The following is a description of a gene set: Human Gene Set: HP_FACIAL_HEMANGIOMA Facial hemangioma Hemangioma, a benign tumor of the vascular endothelial cells, occurring in the face. species: Homo sapiens, and this is the list of marker genes: POR, SLC26A2, VPS35L, GNA14, GLI3, WASHC5, SETBP1, ASXL1, RASA1, RBM8A, RECQL4, GNAQ, TRPM3, STAC3, DHCR7, SRD5A3, ESCO2, MGAT2, CD96, PPP1CB, CCDC22, EPHB4, DPYSL5